The following is a description of a gene set: species: Homo sapiens Any process that stops or reduces the rate of an ATP-dependent activity. Human Gene Set: GOBP_NEGATIVE_REGULATION_OF_ATP_DEPENDENT_ACTIVITY, and this is the list of marker genes: OXA1L, SLN (NCBI Gene Id 84783), TP53, TNNI3, TLR9, PLN, VCPKMT, LTF, TSC1, PPIF, UBLCP1, PXK, PAM16, TNNT2